The following is a description of a gene set: species: Homo sapiens Human Gene Set: REACTOME_ACTIVATION_OF_NMDA_RECEPTORS_AND_POSTSYNAPTIC_EVENTS Activation of NMDA receptors and postsynaptic events, and this is the list of marker genes: MAPT, PRKAG1, KPNA2, GRIA2, NEFL, GRIN1, NRG1, LRRC7, GRIN2B, HRAS, MAPK3, TUBB2B, GRIN2A, TUBB8, CAMK2D, CAMKK1, TUBA3C, LIN7C, SRC, GRIN3A (glutamate ionotropic receptor NMDA type subunit 3A), ARHGEF7, TUBA1B, NRGN, GIT1, CAMK2B, PRKAB1, PPM1F, TUBB6, PDPK1, GRIN2D (glutamate ionotropic receptor NMDA type subunit 2D), TUBA4A, LIN7A, TUBA1C, KIF17, PRKAR2A, CREB1, APBA1, TUBA3D, TUBB4A, CAMK2G, KRAS, TUBA1A, GRIN2C, ERBB4, NBEA, PRKAA2, TUBB3, GRIN3B, GRIA3, CAMKK2, PRKAB2, PRKACG, DLG2, TUBB4B, TUBA8, TUBB1, PPM1E, DLG3, PRKAA1, GRIA1, TUBA4B, RPS6KA2, PRKAR1A, TUBB8B, PRKAR1B, TUBA3E, GRIA4, RPS6KA1, ADCY8, PRKAR2B, PRKX, CAMK1, DLG4, TUBB2A, LIN7B, ACTN2, RASGRF1, NRAS, RPS6KA3, RPS6KA6, PRKAG2, PRKAG3, CAMK4, RAC1, CALM1, DLG1, RASGRF2, PRKACA, ADCY1, TUBAL3, PRKACB, CASK, MAPK1, CAMK2A